The following is a description of a gene set: species: Homo sapiens Human Gene Set: REACTOME_TRANSCRIPTIONAL_REGULATION_BY_RUNX2 Transcriptional regulation by RUNX2, and this is the list of marker genes: PSMD3, PSMC2, PSMD6, BAX (BCL2 associated X, apoptosis regulator), PSMC6, RPS27A, RBX1, PPM1D, MSX2, AKT3, HEY2, SMAD4, PSMA2, PPARGC1A, STAT1, TWIST2, HAND2, NKX3-2, PSMC3, YAP1, WWTR1, AKT1, HDAC3, SMURF1, MAF, PSMB5, PSMD12, SKP2, HES1, ZNF521, BGLAP, ADRM1, PSMA7, TWIST1, PSMA3, LGALS3, HEY1, UCMA, ESRRA (NCBI Gene Id 2101), UBA52 (ubiquitin A-52 residue ribosomal protein fusion product 1), PSMA6, MAPK3, PPARGC1B, PSMD7, ITGBL1, HIVEP3, HDAC4, PSMB2, CCND1, PSMC5, AR, MAPK1, PSMD14, CDK4, PSMB6, WWP1, YES1, RB1, CUL1, UBB, PSMC1, COL1A1, SOX9, PSMA5, ESR1, AKT2, RUNX1, GSK3B, SEM1, PSMD8, PSMB1, PSMD13, CBFB, SATB2 (SATB homeobox 2), PSMD2, PSMB4, SRC (SRC proto-oncogene, non-receptor tyrosine kinase), DLX5, PSMB7, PSMC4, HDAC6, PSMA1, CDKN1A, BMP2, PSMD1, CCNB1, CDK1, ABL1, ITGA5, PSMD11, RUNX2, GLI2, PSMB3, PSMA4, STUB1, SMAD1, UBC, SP7, GLI3, SKP1, SMAD6, RBM14, IHH, DLX6, MMP13, NR3C1